The following is a description of a gene set: species: Mus musculus Mouse Gene Set: GOBP_POSITIVE_REGULATION_OF_GOLGI_TO_PLASMA_MEMBRANE_PROTEIN_TRANSPORT Any process that activates or increases the frequency, rate or extent of the transport of proteins from the Golgi to the plasma membrane., and this is the list of marker genes: Acsl3, Rack1, Cln3, Cnst, Atp2c1